Given this list of marker genes E2F7, ID1, ZNF232, ETS1, TNFRSF10B, IL15RA, TNFRSF10A, IL6, FOXC2, FZD8, DUSP7, IL1RAP, IL1R2, FGF2, ITGB6, FST, RBL1, TGFB1, SFRP1, here is a description of the gene set: Genes down-regulated in MCF10A cells (breast cancer) by expression of LSM1 off a letiviral vector. from publication Streicher KL, Yang ZQ, Draghici S, Ethier SP (PMID 17001308) studied in species Homo sapiens Human Gene Set: STREICHER_LSM1_TARGETS_DN Amplification of the 8p11-12 region occurs in 15-20% of breast cancers, but the driving oncogene at this locus has yet to be definitively identified. We mapped the 8p11-12 amplicon in breast cancer cell lines and primary human breast cancers and identified the candidate oncogene human Sm-like protein (hLsm1, LSM1) based on increases in copy number and expression level relative to human mammary epithelial cells. To examine the oncogenic role of LSM1, we overexpressed this gene in MCF10A mammary epithelial cells and inhibited its production in the SUM44 breast cancer cell line, which has a natural amplification and overexpression of LSM1. Our data confirmed that LSM1 is an oncogene from the 8p11-12 amplicon by showing that hLsm1 overexpression induced growth factor-independent proliferation and soft agar colony formation in MCF10A cells, and hLsm1 inhibition in SUM44 cells dramatically reduced soft agar growth. Little is known about hLsm1 function other than its involvement in mRNA degradation; therefore, we used expression microarray analysis to investigate how hLsm1 affects cell transformation in MCF10A and SUM44 cells. We identified numerous genes altered following hLsm1 overexpression common to SUM44 breast cancer cells that play important roles in cell cycle regulation, cell proliferation and other cancer-promoting processes. Future work will continue to characterize these important changes to achieve a more complete understanding of the mechanism of hLsm1's effect on cancer progression.